Given this list of marker genes CDH23, OTOG, ESRP1, CLRN1, USH1G, CEP78, HARS1, MT-TS2, CIB2, OTOGL, SLC9A1, WHRN, ESPN, GPR156, ARSG, KARS1, PCDH15, USH1C, MYO7A, here is a description of the gene set: Vestibular hyporeflexia studied in species Homo sapiens Human Gene Set: HP_VESTIBULAR_HYPOREFLEXIA A general descriptive term that describes impaired functioning of the vestibular apparatus that leads to manifestations such as dizziness or postural imbalance